Given this list of marker genes STON2, SMAP1, DNAJC6, CLTB, SCYL2, UNC119, PROM2, SGIP1, DLL1, AP2B1, GAS7, HIP1R, AP2M1, CCDC32, CLTA, SIGLEC1, PIK3CB, MAGI2, NEU3, STON1, SH3GL3, DGKD, WASL, PIP5K1C, ITSN2, SLC9B2, TNK2, FCHO2, USH1G, AP2A1, FNBP1L, AAK1, LMBRD1 (LMBR1 domain containing 1), GAK, CANX, PICALM, DNM1, UBQLN2, CLTC, SNAP91, GPR107, AP2S1, FCHSD2, ITSN1, FCHO1, BMP2K, INPP5F, ITGA4, AP2A2, DAB2, here is a description of the gene set: species: Homo sapiens Human Gene Set: GOBP_CLATHRIN_DEPENDENT_ENDOCYTOSIS An endocytosis process that begins when material is taken up into clathrin-coated pits, which then pinch off to form clathrin-coated endocytic vesicles.